The following is a description of a gene set: studied in species Homo sapiens Any process that activates or increases the frequency, rate or extent of glycoprotein metabolic process. Human Gene Set: GOBP_POSITIVE_REGULATION_OF_GLYCOPROTEIN_METABOLIC_PROCESS, and this is the list of marker genes: MIR181B1, TCF7L2, CCR7, PAWR, SLC51B, GOLGA2, ABCA2, RAB1B, CHP1, SLC2A10, CCL19, NCSTN, RAMP1, PXYLP1, PLCB1 (NCBI Gene Id 23236), RAB1A, SOAT1, CCL21, IL33, MUSTN1, CTNNB1 (catenin beta 1), IGF1